Given this list of marker genes REC8 (REC8 meiotic recombination protein), FBXO5, CCNB1, TUT7, TRIP13, RXFP2, BRCA2, AURKA (aurora kinase A), DAZL, WASHC5, ZAR1, ZAR1L, EDN1, YTHDF2, RPS6KA2, RAB24, H3-3A, BNC1, ANG, TUBB8, PPP2R1A, FOXO3, DMC1, OOSP2, H3-3B, WEE2, LSM14B, EDNRA (endothelin receptor type A), PDE3A, MOS, SHB (NCBI Gene Id 6461), NPR2, TUT4, EREG, CDC25B, NPPC, SIRT2, here is a description of the gene set: species: Homo sapiens A developmental process, independent of morphogenetic (shape) change, that is required for an oocyte to attain its fully functional state. Oocyte maturation commences after reinitiation of meiosis commonly starting with germinal vesicle breakdown, and continues up to the second meiotic arrest prior to fertilization. Human Gene Set: GOBP_OOCYTE_MATURATION